Given this list of marker genes Dlc1, Fermt2, Arhgef7, Arhgap22, Arhgap9, Arhgef39, Arhgdib, Arhgef15, Mpp7, Ncf1, Dock8, Sh3bp1, Arhgap44, Cyfip2, Pkn1, Emd, Arhgap26, Lbr, Fgd5, Wasf3, Noxa1, Vav1 (vav 1 oncogene), Tagap, Gna13, Pld2, Pik3r2, Cav1, Pak6, Nox3, Swap70, Arhgap10, Noxo1, Esyt1, Arap1, Fam13b, Dock5, Pak4, Plekhg6, Arhgap12, Arhgap15, Arhgap45, Ngef, Dock11, Racgap1, Fam13a, Lamtor1, Arhgap42, Pak3, Wasf1, Rab7, Arhgef10, Prex1, Plekhg3, Vrk2, Ophn1, Mcam, Baiap2l1, Arhgap17, Dock2, Gmip, Arhgap25, Ncf2, Ktn1, Sos2, Cdc42, Depdc1b, Farp1, Arhgap33 (NCBI Gene Id 233071), Vangl1, Cyba, Epha2, here is a description of the gene set: electronically inferred by orthology from the curated human pathway Reactome Pathway: RAC1 GTPase cycle species: Mus musculus part of: RHO GTPase cycle This event has been computationally inferred from an event that has been demonstrated in another species.<p>The inference is based on the homology mapping from PANTHER. Briefly, reactions for which all involved PhysicalEntities (in input, output and catalyst) have a mapped orthologue/paralogue (for complexes at least 75% of components must have a mapping) are inferred to the other species.